Given this list of marker genes SH3BGRL3, RND2, CD226, GPR85, KCTD18, MEF2C, FIP1L1 (factor interacting with PAPOLA and CPSF1), ANAPC16, USP30, CDNF, GPM6B, CNOT6, BDNF, PHF20L1, KCTD4, LATS2, CEP20, TMED7, MEGF10, SMARCB1, PKD2L2, FGF9, STC2, GLIPR1 (GLI pathogenesis related 1), ZC3H12C, ABCG8, FNDC3A, FOXC1, here is a description of the gene set: Human Gene Set: MIR4423_5P studied in species Homo sapiens Genes predicted to be targets of miRBase v22 microRNA hsa-miR-4423-5p in miRDB v6.0 with MirTarget v4 prediction scores > 80 (high confidence targets). from publication Chen Y, Wang X (PMID 31504780)